Given this list of marker genes ALG8, ALMS1, MAGEL2, IRS4, GLIS3, NDN (NCBI Gene Id 4692), CPE, DUOXA2, TSHB, MADD, USP9X, OCA2, HESX1, PROP1, DUOX2, TSHR, LHX4, LHX3 (LIM homeobox 3), TG, SNRPN, IYD, SLC5A5, FOCAD, KCNJ18, NKX2-5, POU1F1, FOXE1 (forkhead box E1), TPO, DIO1, PAX8, THRA, ALB, THRB, TBL1X, TRHR, SECISBP2, here is a description of the gene set: Abnormal circulating thyroid hormone concentration species: Homo sapiens Any deviation from the normal range of the hormones produced by the thyroid gland. Human Gene Set: HP_ABNORMAL_CIRCULATING_THYROID_HORMONE_CONCENTRATION